Given this list of marker genes CARD16, CASP1, SERPINA5, PLAU, KLK8, PLAT, SERPINE1, SERPINB6, here is a description of the gene set: studied in species Homo sapiens A heterodimeric protein complex that contains a protease inhibitor and a protease; formation of the complex inhibits protease activity. Human Gene Set: GOCC_PROTEASE_INHIBITOR_COMPLEX